The following is a description of a gene set: The reactions by which adenosylcobalamin (AdoCbl) and methylcobalamin (MeCbl) cofactors are synthesized and regenerated are annotated here. species: Homo sapiens part of: Cobalamin (Cbl, vitamin B12) transport and metabolism Reactome Pathway: Cobalamin (Cbl) metabolism, and this is the list of marker genes: MMACHC, MMADHC, MTRR, MMUT, MMAB, MMAA, MTR